Given this list of marker genes Ncoa3, Hat1, Naa60, Gtf3c4, Nat8f7, Gtf2b, Naa40, Nat8f3, Clock, Kat6b, Kat7, Kat2b, Kat5, Kat8, Crebbp, Cdyl, Mcm3ap, Kat6a, Ncoa1, Ep300, Kat2a, Ing3 (inhibitor of growth family, member 3), Taf1, here is a description of the gene set: species: Mus musculus Catalysis of the reaction: acetyl-CoA + histone H2A L-lysine = CoA + histone H2A N6-acetyl-L-lysine. Mouse Gene Set: GOMF_HISTONE_H2A_ACETYLTRANSFERASE_ACTIVITY